Given this list of marker genes DNAJC9, RNF38, HES6, OMA1, EIF3I, LCN8, IARS2, ODR4, NCF2, APOE, TMEM203, GRIN2B, NR2C2AP, MRPL2, MRPL41, ANKRD13A, IL7R, PXMP2, AATF, SPMIP10, C14orf119, ZNF362, CLEC5A, TCF12, RPP21, KPNA2, PHAF1, PISD, TMEM42, B3GALNT1, CSNK1G2, RDH13, FAM50A, EMP3, LDHA, PGLYRP1, C6orf136, NDUFS6, ITCH, RACK1, RPL26, PCMTD2, C19orf53, MEA1, BCL2L11, PDCD2, SIGIRR, DOLPP1, TMEM14C, CEP20, TEP1, N4BP2L1, ZMIZ2, SLC2A8, PKIB, ASH2L, TRAPPC12, FANCL, ZNF276, CEP55, NDUFV2, ADCY9 (adenylate cyclase 9), H2AC25, FGF13, NEK9, HMGB1, GPR180, GLE1, EXOC7, KDELR1, HCFC1R1, AFG3L2, MGST1, PPP1R14B, ST7L, SEPTIN10, PDGFD, PRDX2, CAMTA2, BCAS2, PCYT1A, GPN1, KDM6A, DCTPP1, MBL2, MRPL40, PSMD4, FERRY3, ARL6IP4 (NCBI Gene Id 55913), SREBF1, KCTD12, ECI1, SRP19, PRKDC, NDUFS8, ARMC1, TRIM27, METTL5, TMEM134, NEMF, DNPEP, PPP1R15A, PXMP4, NR1I3, RASAL2, TECPR1, UNC119, TMEM141, LPIN2, VARS1, RPGRIP1, CCR1, POLK, BET1, NUP88, DENND10, NMRK1 (nicotinamide riboside kinase 1), TSC22D3, MTMR3, AIF1, EEF1G, VAMP8, EMC6, HAUS5, CD164, POLR2E, ETFBKMT, MIDN, OPN3, C3orf70, GMFB, MRPL12, STAB1, ANAPC2, STOM, EIF4G3, EIF3H, LTB, NSMAF, ST6GALNAC4, TIMM8A (translocase of inner mitochondrial membrane 8A), SCX, RASSF8, PDHA2, UCK2, SYNJ2BP, DDX18, PARP1, MICAL1, PRPS1, TRIAP1, WDSUB1, AIFM1, IFI30, HDAC5, RACGAP1, XRCC1, KIF2A, FRRS1, KCNAB2, CELSR1, SERINC3, FEZ2 (fasciculation and elongation protein zeta 2), VPS11, PRCP, TGIF2, NT5M, SNX3, ZNF287, ORAI1, SNAPIN, INPP4A, CCDC80, MRPS33, TNRC6A, AHCYL2, MEF2D, ORC6, DPP3, PARP16, APP, DNAJA3, GNL3, SLC25A11, BIN3, FZR1, MBD3, ACTR1A, DUS1L, CPT1A, XPO7, H2AX, MALAT1, SMAD4, FGFR1OP2, TNFRSF12A, KLF4, BCL2L14, MCM7, here is a description of the gene set: Human Gene Set: GSE17721_LPS_VS_POLYIC_4H_BMDC_DN from publication Amit I, Garber M, Chevrier N, Leite AP, Donner Y, Eisenhaure T, Guttman M, Grenier JK, Li W, Zuk O, Schubert LA, Birditt B, Shay T, Goren A, Zhang X, Smith Z, Deering R, McDonald RC, Cabili M, Bernstein BE, Rinn JL, Meissner A, Root DE, Hacohen N, Regev A (PMID 19729616) mouse primary BMDCs were stimulated with tlr ligands and gene expression changes were profiled on Affymetrix arrays Genes down-regulated in comparison of dendritic cells (DC) stimulated with LPS (TLR4 agonist) at 4 h versus DC cells stimulated with poly(I:C) (TLR3 agonist) at 4 h. studied in species Homo sapiens